The following is a description of a gene set: Genes up-regulated in primary B lymphocytes engineered to overexpress BCL2. Mouse Gene Set: VANASSE_BCL2_TARGETS_UP studied in species Mus musculus The t(14;18)(q32;q21), resulting in deregulated expression of B-cell-leukemia/lymphoma-2 (Bcl-2), represents the genetic hallmark in human follicular lymphomas. Substantial evidence supports the hypothesis that the t(14;18) and Bcl-2 overexpression are necessary but not solely responsible for neoplastic transformation and require cooperating genetic derangements for neoplastic transformation to occur. To investigate genes that cooperate with Bcl-2 to influence cellular signaling pathways important for neoplastic transformation, we used oligonucleotide microarrays to determine differential gene expression patterns in CD19+ B cells isolated from Emu-Bcl-2 transgenic mice and wild-type littermate control mice. Fifty-seven genes were induced and genes were repressed by > or =2-fold in Emu-Bcl-2 transgenic mice (P < 0.05). The suppressor of cytokine signaling-3 (SOCS3) gene was found to be overexpressed 5-fold in B cells from Emu-Bcl-2 transgenic mice. Overexpression of Bcl-2 in both mouse embryo fibroblast-1 and hematopoietic cell lines resulted in induction of SOCS3 protein, suggesting a Bcl-2-associated mechanism underlying SOCS3 induction. Immunohistochemistry with SOCS3 antisera on tissue from a cohort of patients with de novo follicular lymphoma revealed marked overexpression of SOCS3 protein that, within the follicular center cell region, was limited to neoplastic follicular lymphoma cells and colocalized with Bcl-2 expression in 9 of 12 de novo follicular lymphoma cases examined. In contrast, SOCS3 protein expression was not detected in the follicular center cell region of benign hyperplastic tonsil tissue. These data suggest that Bcl-2 overexpression leads to the induction of activated signal transducer and activator of transcription 3 (STAT3) and to the induction of SOCS3, which may contribute to the pathogenesis of follicular lymphoma. from publication Vanasse GJ, Winn RK, Rodov S, Zieske AW, Li JT, Tupper JC, Tang J, Raines EW, Peters MA, Yeung KY, Harlan JM (PMID 15561778), and this is the list of marker genes: Srp54a, Ighv7-1, H1f2, Gnas, Nr2f2, Ryr2, Slc16a9, Ppp1r2, Ighg3, Map3k6, Serping1, Iglv3, C2, Cwc22, Sostdc1, Fam209, Jchain, Lifr, Hspa4l, Ccr9, Slpi, Lancl1, Kng1, Basp1, Pilra, Il1rn, Ighm, Hspa1a, Prdm1, Apoa2, Mbnl2, Pon3, Reln, Macc1, Ighg2b